Given this list of marker genes MAPK1, JUN, FOS, MMP9, MAPK3, here is a description of the gene set: HBV HBx to ERK signaling pathway. Pathway ID: N00545. Pathway type: Pathogen. Pathway class: nt06263 Hepatocellular carcinoma. Human Gene Set: KEGG_MEDICUS_PATHOGEN_HBV_HBX_TO_ERK_SIGNALING_PATHWAY studied in species Homo sapiens Pathway Definition from KEGG: X -> ERK -> AP1 => MMP9